The following is a description of a gene set: Any process carried out at the cellular level that reduces or removes the toxicity of an aldehyde. These may include transport of aldehydes away from sensitive areas and to compartments or complexes whose purpose is sequestration of the toxic substance. species: Homo sapiens Human Gene Set: GOBP_CELLULAR_DETOXIFICATION_OF_ALDEHYDE, and this is the list of marker genes: ALDH1A1, RDH11, ESD, PARK7, ADH4, ADH5, RDH12, AKR1A1, AKR1B10